The following is a description of a gene set: Human Gene Set: GOBP_CARDIOBLAST_PROLIFERATION studied in species Homo sapiens The multiplication or reproduction of cardioblasts, resulting in the expansion of the population in the heart field. A cardioblast is a cardiac precursor cell. It is a cell that has been committed to a cardiac fate, but will undergo more cell division rather than terminally differentiating., and this is the list of marker genes: MKS1, TBX5, CTNNB1, SIX1, NOTCH1, HES1, EYA1, MIR20A, HAND2, ISL1, PIM1